Given this list of marker genes CDC45, MCM7, GINS3, GINS4, GINS2, MCM6, MCM3, GINS1, MCM4, MCM2, MCM5 (minichromosome maintenance complex component 5), here is a description of the gene set: Human Gene Set: GOCC_CMG_COMPLEX species: Homo sapiens A protein complex that contains the GINS complex, Cdc45p, and the heterohexameric MCM complex, and that is involved in unwinding DNA during replication.